The following is a description of a gene set: Mouse Gene Set: GOMF_INWARD_RECTIFIER_POTASSIUM_CHANNEL_ACTIVITY species: Mus musculus Enables the transmembrane transfer of a potassium ion by an inwardly-rectifying voltage-gated channel. An inwardly rectifying current-voltage relation is one where at any given driving force the inward flow of K+ ions exceeds the outward flow for the opposite driving force. The inward-rectification is due to a voltage-dependent block of the channel pore by a specific ligand or ligands, and as a result the macroscopic conductance depends on the difference between membrane voltage and the K+ equilibrium potential rather than on membrane voltage itself., and this is the list of marker genes: Kcnh3, Kcnj14, Kcnj1, Kcnh2, Kcnj9, Cav1, Kcnj6, Kcnj5, Kcnk1, Kcnj2, Kcnj8, Kcnh7, Kcnj10, Kcnj3, Kcnn2, Kcnj15, Kcnh6, Kcnj13, Kcnj11, Kcnn1, Kcnj4, Kcnn3, Kcnj16, Kcnj12, Kcnn4, Kcne2